The following is a description of a gene set: species: Mus musculus Dectin-2 family Mouse Gene Set: REACTOME_DECTIN_2_FAMILY, and this is the list of marker genes: Lyn, Fcer1g (NCBI Gene Id 98395), Syk, Clec4d, Fyn, Plcg2, Clec4n, Clec4e